Given this list of marker genes PWRN1, WNT5A, NDN, MKRN3, RAB3GAP1, SETBP1 (NCBI Gene Id 284262), RAB18, DVL1, ROR2, TBC1D20 (NCBI Gene Id 170488), POR, CDT1, SIM1, GMNN, FGFR2, SNORD116-1, NPAP1, MAGEL2, PWAR1, ATIC, SNRPN, ACTB, MAB21L1, TWIST2, ORC1, DVL3, ORC6, OCA2, FZD2, SNORD115-1, GAD1, ORC4, CDC45, CDC6, RAB3GAP2, HERC2, ESCO2, KAT6B, ZFPM2, here is a description of the gene set: species: Homo sapiens Human Gene Set: HP_ABNORMAL_LABIA_MINORA_MORPHOLOGY An anomaly of the labia minora, the folds of skin between the outer labia. Abnormal labia minora morphology